Given this list of marker genes Otulinl, Alg13 (NCBI Gene Id 72688), Pkd2, Sppl2c, Rpl27, Alg5, Alg2, Rps28, Sppl3, Rps29, Sppl2a (NCBI Gene Id 66552), Gnrh1, Sppl2b, Epm2aip1, Itpr3, H13, Alg14, Ptpn1, Rps26, Epm2a, Alg1, here is a description of the gene set: species: Mus musculus Mouse Gene Set: GOCC_CYTOPLASMIC_SIDE_OF_ENDOPLASMIC_RETICULUM_MEMBRANE The side (leaflet) of the plasma membrane that faces the cytoplasm.